Given this list of marker genes LAMB2, COL5A1, COL11A2, HAPLN1, PXDN, ITIH1, CILP, COL8A2, COL10A1, COL8A1, EMILIN2, ITIH2, LOXL4, EMILIN3, CSPG4, SERPINE2, COL28A1, HMCN1, here is a description of the gene set: species: Homo sapiens from publication Naba A, Clauser KR, Hoersch S, Liu H, Carr SA, Hynes RO (PMID 22159717) Matrisome proteins exclusively detected in highly metastatic melanoma human-to-mouse xenografts (A375_MA2) in comparison to poorly metastatic melanoma human-to-mouse xenografts (A375). We employed a proteomic strategy developed to characterize the in-vivo ECM composition of normal tissues and tumors using enrichment of protein extracts for ECM components and subsequent analysis by mass spectrometry. We grew subcutaneous tumors by injection into NOD/SCID/IL2R? mice of A375 human melanoma cells (poorly metastatic) or their highly metastatic derivatives MA2. The tumors were dissected 5 weeks later, and the tumor ECM was enriched and analyzed using mass spectrometry. We define the tumor ECM as the ensemble of ECM proteins and ECM-associated proteins found in two independent samples. A challenging question when studying the tumor microenvironment is to understand the origin of the tumor ECM; that is, whether the tumor ECM is produced and secreted by the tumor cells themselves, by the stromal cells or by both compartments. To address this question, we pursued the analysis of the melanoma xenografts described above, by identifying the origin of each protein. In order to be able to identify without ambiguity the origin of each protein, we required that proteins needed to be detected in two independent samples with at least two species-specific peptides in one of them. Using this strategy, we identified for each tumor type a set of matrisome proteins exclusively secreted by the (human) tumor cells, and another set exclusively secreted by the (murine) stromal cells. This gene set lists the matrisome proteins (based on the criteria mentioned above) secreted by the tumor cells and stromal cells in MA2 tumors and not in A375 tumors. Human Gene Set: NABA_MATRISOME_HIGHLY_METASTATIC_MELANOMA